Given this list of marker genes RRP12, WFS1, SIN3B, CXXC5, MPPED2, CHSY1, NIP7, LMO1, FKBP4, AXIN1, DEGS2, NCOR2, SLC7A5, B4GALT1, STC2, AP1B1, CAMTA1, IER5L, DOK7, SULT2B1, INO80B, WDR46 (WD repeat domain 46), SYNDIG1, CELSR2 (NCBI Gene Id 1952), CYP4F22, A4GALT, CYP4F11, NT5DC3, NOL6 (nucleolar protein 6), VWF, TENT5C, RET, DEPTOR, ATP6V1C2, SLC2A1, SVIL, OLFML3, MAT2A, RAPGEFL1, TSKU (tsukushi, small leucine rich proteoglycan), ALPL, GNL2, RPUSD1, GAB2, PTGES, SCNN1A, AUNIP, OSGIN1, LRG1, HK2, SCNN1B, FOXC1, TRMT61A, SLC2A8, UNC119, E2F6, CARD19, SLC22A5, SMTNL2, FCMR, SNX24, PITX1, SH2B2, ARHGEF18, SLC25A19, CCDC3, UBIAD1 (NCBI Gene Id 7801), NXT1, CYP1B1, RIMS4, TIAM1, SRM, GFOD1, NHERF1, FGFRL1, CA12, LRIG1, ZNF185, TH, THOC5, TJP3, ACIN1, ASB13, SLC1A4, MYB, POLR1B, MLPH, FHL2, SPATS2L, CBFA2T3, TMPRSS3 (transmembrane serine protease 3), ADCY9, DHRS2, PGR, NCS1 (neuronal calcium sensor 1), OVOL2, GPR68, SH2D2A (NCBI Gene Id 9047), CHD9, XBP1, ACSS1, SEC14L2, FLNB, IL20, KDM4B, TPD52L1, FRK, HPDL, MAG, SOX3, SOX8, CHST8, RCL1, RPP40, GPATCH4, CDK5R1, C1QTNF6, UHRF1, SUSD3, MSMB, CNKSR3, EEIG1, GINS3, ISG20L2, GPRIN1, TMEM104, MED24, PKIB, LONRF2, TGM2, CISH, SNAPC4, SYBU, UNC5A, KLK10, TGIF2, CDC6, SIAH2, SEMA3B, KRT15, MYEOV, SMOX, UST, PTH1R, HCK, TUBB2B, KAZN, PRSS23, MFSD2A, SLC29A1, ZNF703 (zinc finger protein 703), PLEKHH1, MREG, IFRD1, MCM10 (NCBI Gene Id 55388), CCM2L, AMZ1, KCNK6, PIP4K2A, WWC1, MANEAL (mannosidase endo-alpha like), P2RY2, MYBBP1A, HR, LETM1, ADAMTSL5, POP1 (NCBI Gene Id 23044), TMEM51, TIPARP, SYTL4, PMM2, PHLDA2, PGBD5, BHLHE40, AHCTF1, NMRK1, REEP1, TSEN54, COLGALT1, BCL11B, SPINK4, XRCC3, PPARGC1B, NXNL2, NUDCD1, RARA, IGFBP4, PDZK1, C16orf74, FARP1, TBKBP1, SHB, CCND1, KHK, RAB3IL1, DHRS3, NOLC1, NEIL2, PRR5, PDLIM3, E2F2, TFF2, PPRC1, GSG1L (GSG1 like), GREB1, LHX6, TRIM47, SLC47A1, MORC4, PADI3, LHX4, here is a description of the gene set: from publication Bhat-Nakshatri P, Wang G, Appaiah H, Luktuke N, Carroll JS, Geistlinger TR, Brown M, Badve S, Liu Y, Nakshatri H (PMID 18838536) species: Homo sapiens Genes bound by ESR1 and up-regulated by estradiol in MCF-7 cells (breast cancer). Human Gene Set: BHAT_ESR1_TARGETS_NOT_VIA_AKT1_UP Estrogen regulates several biological processes through estrogen receptor alpha (ERalpha) and ERbeta. ERalpha-estrogen signaling is additionally controlled by extracellular signal activated kinases such as AKT. In this study, we analyzed the effect of AKT on genome-wide ERalpha binding in MCF-7 breast cancer cells. Parental and AKT-overexpressing cells displayed 4,349 and 4,359 ERalpha binding sites, respectively, with approximately 60% overlap. In both cell types, approximately 40% of estrogen-regulated genes associate with ERalpha binding sites; a similar percentage of estrogen-regulated genes are differentially expressed in two cell types. Based on pathway analysis, these differentially estrogen-regulated genes are linked to transforming growth factor beta (TGF-beta), NF-kappaB, and E2F pathways. Consistent with this, the two cell types responded differently to TGF-beta treatment: parental cells, but not AKT-overexpressing cells, required estrogen to overcome growth inhibition. Combining the ERalpha DNA-binding pattern with gene expression data from primary tumors revealed specific effects of AKT on ERalpha binding and estrogen-regulated expression of genes that define prognostic subgroups and tamoxifen sensitivity of ERalpha-positive breast cancer. These results suggest a unique role of AKT in modulating estrogen signaling in ERalpha-positive breast cancers and highlights how extracellular signal activated kinases can change the landscape of transcription factor binding to the genome.